The following is a description of a gene set: Any process that activates or increases the frequency, rate or extent of long-term synaptic potentiation. Human Gene Set: GOBP_POSITIVE_REGULATION_OF_LONG_TERM_SYNAPTIC_POTENTIATION studied in species Homo sapiens, and this is the list of marker genes: SLC18A3, SHANK3, INS, LGMN, CHRNA7, ZDHHC2, RELN, ADCY1, EIF2AK4, STAU1, EPHB2, NRGN, ADORA2A, ADCY8, SQSTM1, PDE9A (NCBI Gene Id 5152), SHISA7, APP, CREB1, MME, IGSF11, AKAP5, PRKAR1B, DRD2